The following is a description of a gene set: Human Gene Set: REACTOME_INTERACTION_WITH_CUMULUS_CELLS_AND_THE_ZONA_PELLUCIDA Interaction With Cumulus Cells And The Zona Pellucida studied in species Homo sapiens, and this is the list of marker genes: SPAM1, B4GALT1, OVGP1, ADAM30, ZP2, ZP4, ZP1, ADAM2, ADAM21, ZP3, ADAM20